The following is a description of a gene set: Human Gene Set: GOBP_REGULATION_OF_MITOTIC_SISTER_CHROMATID_SEGREGATION studied in species Homo sapiens Any process that modulates the frequency, rate or extent of sister chromatid segregation during mitosis., and this is the list of marker genes: SKA3, APC, BUB1B, TTK, USP44, PRAP1, CDCA8, BECN1, BIRC5, IK, KAT5 (NCBI Gene Id 10524), MAD2L1BP, NDC80, DYNC1LI1, GEN1, MAD2L2, LCMT1, ZW10, PSMG2, TRIP13, KNTC1, DUSP1, SPC25, RAD21, CDK1, MAD1L1, ZNF207, ANAPC15, SKA1, KLHL22, PLK1, ATM, FBXO5, CCNB1, CDC20, SPDL1, CDK5RAP2, XRCC3, KAT2B, BUB1, TEX14, ZWINT, MAD2L1, BUB3, NUF2, INCENP, HNRNPU, KNL1, AURKB, TPR, CENPF, ZWILCH, NUMA1, PRP4K, HASPIN, SIRT1, SPC24